The following is a description of a gene set: Genes predicted to be targets of miRBase v22 microRNA hsa-miR-4700-5p in miRDB v6.0 with MirTarget v4 prediction scores > 80 (high confidence targets). Human Gene Set: MIR4700_5P from publication Chen Y, Wang X (PMID 31504780) studied in species Homo sapiens, and this is the list of marker genes: EFCC1, NFYC, ARL10 (NCBI Gene Id 387489), CELF6, DNAJC15, AKIRIN1, PCDHGB2, MBD6, SLC27A4 (NCBI Gene Id 9176), SORCS2, CARMIL3, VCF2, S1PR2, FBXO41, FGF19, DMWD, PCDHGA7, CALN1, NAV1, PPP1R10, CNTN2, THRA, FOXN3, DNALI1, PRKAR1B, PCDHGB3, ZNF346, ANKRD20A1, TEX36, PCDHGB7, PRH2, CLDN19, NAA40, ARFIP1, PCDHGC5, HSF2BP, MAT2A, MTHFR (methylenetetrahydrofolate reductase), FUT11 (fucosyltransferase 11), ATF6B, DCTN5, HEYL, PCDHGB5, MTCL2 (microtubule crosslinking factor 2), MKRN2, TRIM71, PPP1R1B, CCSER2, RALGPS1, TBKBP1, PPP1CA, PAK6-AS1, SALL1, MMUT, SEMA3F, ENTPD3, SLC25A14, DUSP9, ACACA (NCBI Gene Id 31), ZNF106, GFAP, GLIPR1, ANKIB1, DGAT2, CIC, PSMD5, CCDC178, VTI1A, PRKCG, TSPAN11, OSBPL7, FAM228B, ZNF704, SON, TOX3, MAP3K14, PSMF1, KDELR1, UNC5B, NHLH1 (NCBI Gene Id 93188), RARB, ELMOD1, LZTS3, PRX, PMS2, LZTS1, GALNT15, POPDC3, CDC42EP1, SAMD12, TMEM127 (transmembrane protein 127), PALM, PCDHGC3, PCDHGA8, CSKMT, DNM1L, SUPT7L, POU3F3 (POU class 3 homeobox 3), PCDHGA6, LASP1, TBX5, TTF2, RCAN2, ITPRIP, CAPN12, KSR2, BAK1, EHD3, STX17, SEPTIN5, UBXN4, SMYD1, BCL2L1, MS4A15, PCDHGC4, SAP30BP, CIITA, NR6A1, SSX1, TET3, PCDHGA1, PCDHGA5, SLC38A7, APOM, SERPINA1, ZNF687, GLP1R, PCDHGA4, SORT1, IL6R, ANKRD20A2P, PCDHGA10, BBIP1, PCDHGB6, MEIS2, ABCC10, PCDHGB1, ATXN1L, AAK1, PCDHGA2, STAM2, TSPAN2, GIGYF1, SUSD2, SRM, ZDHHC23, SPIB, LOXHD1, NAGA, PCDHGA9, DAGLA, TJP1, ZNF831, FGF18, GAB2, ANKRD20A4P, VSTM4, SGCD, PCDHGA3, ABCB9, LYPD6, WDR72, PADI2, PXN, MBOAT7, ITGA5, ZNF474, MAT1A, SLC34A2, UBE2L6, PPP1R9B, GRIP2, HACD3, SNX12, CPLX2, RASSF4, CNGB1, SLC17A2, C17orf107, NCDN, CLSTN1, TEAD1, KCNJ10, RNASE13, TBC1D13, PCDHGA12, SOX6, CASKIN1, HCCS, IQSEC3, RNF170, EFR3B, XPO7 (exportin 7), GGA3, SLC6A9, C2CD2L, RANBP1 (RAN binding protein 1), CARTPT, NRIP2, CD44, FBLN1, NUMA1, ARID3B, PCDHGA11, KCNK3, SH2D3C, SRCAP, EGLN3, PCDHGB4, MAPK1, MLLT6, RGSL1, ZNF559, OPRM1, RARG, KCNMA1